Given this list of marker genes CERKL, SDCCAG8, TIMM8A, CC2D2A, CACNA2D4, PCYT1A, WWOX, PEX1, TRIM32, TTLL5 (tubulin tyrosine ligase like 5), RPE65, RD3 (RD3 regulator of GUCY2D), DNAJC30, EMC1, OPN1MW, POGZ, KIAA1549, MT-ND4, PROM1 (NCBI Gene Id 9634), EYS, GNB5, PRPF31, AGK, ABCA4, ADAR, CFAP410, GNAT2, KIF3B, SPATA7, PDE6G, SNRNP200, NMNAT1 (NCBI Gene Id 64802), SLC25A4, PRCD, GPR179, OPN1LW, CAPN5, BEST1, ARL2BP, TTC8, TUB, VSX1, HGSNAT, GRK1, FSCN2, ARHGEF18, DHDDS, MT-TS2, LRAT, ATF6, HADHA, RP1L1, CEP290, KIZ (NCBI Gene Id 57166), MT-ND6, POC1B (POC1 centriolar protein B), OFD1, FOXC1, WDPCP, CABP4, PDE6C, MKKS, CNGB3, RDH12, IMPG1, SCLT1, IFT74, ACOX1, ARL6, RP1, GUCA1A, NUP54, RIMS1 (NCBI Gene Id 22999), CFAP418, ALG3, MT-CYB, TRIM44, CRB1, NRL, NOTCH3, MT-ND1, ZNF408, BBS2, CACNA1F, PRPF6, CHM, AIPL1, TLCD3B, BBIP1, IFT172, FAM161A, RHO, TRPM1, AHI1, PRPH2, NUP62, PPT1, LARGE1, IDH3A, PDE6D, RP2, CWC27, USH1G, MCOLN1, BBS9, IFT27, SSBP1, KCNJ13, PHOX2A, CNGB1, RNF216, MT-CO3, COL25A1, MFRP, RAX2, KLHL7, PDE6A, MYO7A, TKFC, CLRN1, SAG, CEP104, ADGRV1, BBS4, CLN8, RPGR, IMPDH1, SLC24A1, BBS7, PIEZO2, CIB2, PDE6B, RPGRIP1, HARS1, IMPG2, CLCC1, IQCB1, NPHP1, IFT140, FLVCR1, CNGA1, USH2A, NEK2, PAX6, ARSG, DHX38, CDHR1, MERTK, AGBL5, PNPLA6, GDF6, AHR, OPN1SW, USH1C, RP9, TUBB4B, ROM1, LZTFL1, UNC119, PCARE, RGR, TUBB2B, CRX, BBS5, BBS10, PEX12, MT-ATP6, TOPORS, RLBP1, PRPF4, PDE6H, RAB28, SEMA4A, TUBA1A, GNAT1, TULP1, TUBB3, CLN3, IFT88, RDH5, CDH23, IDH3B, GNB3, REEP6, CEP19, RBP3, DRAM2, BBS1, ADAM9, ARL3, TPP1, GUCA1B, NYX, MKS1, SUCLA2, IDS, LRIT3, GRM6, MT-ND2, GUCY2D (guanylate cyclase 2D, retinal), RS1, PRPF8, KIF21A, PDZD7, CEP78, TIMP3, CA4, PRPF3, MT-ND5, NR2E3, ESPN, ZNF699, WHRN, CNGA3, PCDH15, ZNF513, LCA5, MT-CO1, SCAPER, HSD17B4, POMGNT1, CYP4V2, SLC7A14, BBS12, PITPNM3, NDUFS2, USP45, MT-ND4L, MAK, here is a description of the gene set: species: Homo sapiens Human Gene Set: HP_ABNORMAL_ELECTRORETINOGRAM Any abnormality of the electrical responses of various cell types in the retina as measured by electroretinography. Abnormal electroretinogram